The following is a description of a gene set: species: Homo sapiens Reactome Pathway: Acyl chain remodelling of PE In the acyl chain remodelling pathway (Lands cycle), phosphatidylethanolamine (PE) is hydrolyzed by phopholipases and subsequently reacylated by acyltransferases. These cycles modify the fatty acid composition of glycerophospholipids to generate diverse molecules asymmetrically distributed in the cell membrane. part of: Glycerophospholipid biosynthesis, and this is the list of marker genes: MBOAT1 (NCBI Gene Id 154141), PLA2G2A, MBOAT2, PLA2G2F, PLA2G1B, PLAAT2, LPCAT4, ABHD4, PLA2R1, PLAAT5, PLA2G4B, PLA2G10, PLAAT3, PLAAT4, PLA2G4C, LPCAT3, PLA2G2E, PLA2G4F, PLAAT1, PLA2G4D, PLBD1, PLA2G5, PNPLA8, PLA2G6, PLA2G4E, PLA2G3, PLA2G12A, PLA2G4A, PLA2G2D